The following is a description of a gene set: Third degree atrioventricular block Third-degree atrioventricular (AV) block (also referred to as complete heart block) is the complete dissociation of the atria and the ventricles. Third-degree AV block exists when more P waves than QRS complexes exist and no relationship (no conduction) exists between them. studied in species Homo sapiens Human Gene Set: HP_THIRD_DEGREE_ATRIOVENTRICULAR_BLOCK, and this is the list of marker genes: LMNA, GRIN1, PTPN11, RRM2B, DEF6, SCN5A, MYL4, PRKG2, TBX5, MT-TL1, DES, MT-ATP8